Given this list of marker genes Osbpl8, Vxn, Tgfbr1, Ankrd28, Fbrs, Zfp608, Hif3a, P2rx5, Rgs8, Vezf1, Etaa1, Thsd7a, Anxa9, G6pdx, Mmp3, Isca1, Cdc27, Pi4kb, Cnot8, Sh3pxd2a, Kctd6, Tgfb3, Ccdc137 (NCBI Gene Id 67291), Kcnrg, Polr2a, Sft2d2, Mmab, Smad2, Lrsam1, Zfp831, Ppp1r3b, Zfp677, Rpp14, Odc1, Hsd17b8, Mtr (5-methyltetrahydrofolate-homocysteine methyltransferase), Nacc2, Cibar1, Mrtfb, Fcgr1, Ica1l, Fam78b, Pygo2, Cdip1, Smoc1, Xlr3a, Pld1, Syne1, Cbx5, Sprr2e, Phlpp1, Tgm3, Luzp1, Galnt5, Arhgef15, 1810065E05Rik, Lrrc74b, Bricd5, Gipr, Alpk3, Abl2, Camk2g, Dtx4, Sema6a, Larp1, Slc39a11, Pex19, Creb1 (NCBI Gene Id 98624), Smoc2, Agap1, Cyp2j13, Phospho1, Atp6v1g1, Rab3c, Plcxd2, Pbx3, Rad54l2 (RAD54 like 2 (S. cerevisiae)), Xlr3b, Iffo2, Glt8d2, Lsm11, Muc13, 1700030K09Rik, Irf2bp2, Zfp719 (NCBI Gene Id 77372), Ccdc62, Amn, Fzd7, Wdfy4, Xlr3c, Shoc2, Dtx3l (deltex 3-like, E3 ubiquitin ligase), Dock4, Thrb, Ppp4r3b, Mau2, Pnkd, Pramel24, Ano3, Gm7694, Kansl3, Ppp2r1b, Ubap2l, here is a description of the gene set: Mouse Gene Set: MIR_6909_3P from publication Chen Y, Wang X (PMID 31504780) Genes predicted to be targets of miRBase v22 microRNA mmu_miR_6909_3p in miRDB v6.0 with MirTarget v4 prediction scores > 80 (high confidence targets). studied in species Mus musculus